The following is a description of a gene set: Down-regulated genes in the expression signature of aneuploidy in uveal melanoma tumors: low vs high aneuploidy. Human Gene Set: EHLERS_ANEUPLOIDY_DN species: Homo sapiens PURPOSE: Aneuploidy is a hallmark of cancer and is closely linked to metastasis and poor clinical outcome. Yet, the mechanisms leading to aneuploidy and its role in tumor progression remain poorly understood. The extensive and complex karyotypic abnormalities seen in many solid tumors could hinder the identification of pathogenetically relevant chromosomal alterations. Uveal melanoma is an attractive solid tumor for studying aneuploidy because it is a relatively homogeneous cancer that is highly metastatic and has low nonspecific chromosomal instability. EXPERIMENTAL DESIGN: Comparative genomic hybridization and gene expression profiling were used to analyze patterns of aneuploidy in 49 primary uveal melanomas. This analysis was supplemented by a review of cytogenetic findings in 336 published cases. RESULTS: Three prognostically significant tumor subgroups were identified based on the status of chromosomes 3 and 6p. Discrete patterns of chromosomal alterations accumulated in these three subgroups in a nonrandom temporal sequence. Poor clinical outcome was associated with early chromosomal alterations rather than overall aneuploidy. A gene expression signature associated with aneuploidy was enriched for genes involved in cell cycle regulation, centrosome function, and DNA damage repair. One of these genes was PTEN, a tumor suppressor and genomic integrity guardian, which was down-regulated in association with increasing aneuploidy (P = 0.003). CONCLUSIONS: The relationship between aneuploidy and poor prognosis may be determined by specific, pathogenetically relevant chromosomal alterations, rather than overall aneuploidy. Such alterations can be identified using integrative genomic methods and may provide insights for novel therapeutic approaches. from publication Ehlers JP, Worley L, Onken MD, Harbour JW (PMID 18172260), and this is the list of marker genes: PRELP, CNIH4, GMPR, ANO6 (NCBI Gene Id 196527), CA14, GPAT4, FZD9, GABRB3, NCS1, PTRH2, RNF144A (ring finger protein 144A), LY6E